Given this list of marker genes CIB1, MYO1C, MIEF1, ERBB2, C2CD5, ANK3, SLC51B, ITGB2, TCAF2, ITGAM, GDI1, MTCL1, ITGB1BP1, DMTN, KCNE1, HPCA, STOM, USP17L2, HRAS, KCNB1, SLC1A1, CHP1, PDZK1, TCAF1, CEMIP, FYN, INPP5K, CDK5R1, PRNP, CDK5, PAK1, AKT2, MIEF2, here is a description of the gene set: Human Gene Set: GOBP_REGULATION_OF_PROTEIN_TARGETING_TO_MEMBRANE Any process that modulates the frequency, rate or extent of the process of directing proteins towards a membrane, usually using signals contained within the protein. species: Homo sapiens